The following is a description of a gene set: species: Homo sapiens Human Gene Set: GSE18893_CTRL_VS_TNF_TREATED_TCONV_24H_DN Here we show that tumor necrosis factor (TNF) induced in human T-regulatory cells (Treg), as compared to conventional T cells (Tcon), a transcription program highly enriched for typical NF-κB target genes, such as: the cytokines LTA and TNF; the TNF-receptor super family members FAS, 4-1BB and OX-40; various anti-apoptotic genes; and other important immune-response genes. As an initial approach to examine the cellular program induced by TNF in Tregs versus Tcon cells, we employed microarray gene expression analysis at 2 and 24 hrs following TNF treatment. Genes down-regulated in T conv cells (24h): medium versus TNF. from publication Nagar M, Jacob-Hirsch J, Vernitsky H, Berkun Y, Ben-Horin S, Amariglio N, Bank I, Kloog Y, Rechavi G, Goldstein I (PMID 20181891), and this is the list of marker genes: BCAS3, DDR1, LGALS4, APC, RNF169, GM2A, NRP1, POLD4, CYP4B1, ZFAND5, TBC1D12, RCVRN, RPS6KB2, SLC26A11, HPS3, ESRRB, CENPJ, MOGAT2, RALBP1, FGFBP1, ITGA1, RWDD2A, PRKAR1A, BCORL1, UBXN7 (NCBI Gene Id 26043), PID1, APOLD1, TAF13, POU2AF2, AP3M2, ZDHHC2, ENTREP1, ASPSCR1, PLEKHM3, SCNN1A, TRIM24 (tripartite motif containing 24), TSPO2, PHYHIPL, ZNF454, CFAP119, UBE2B, SPRING1, LIMS4, ABI1, RSRP1, CYTL1, JUNB, TCEANC2, IL21, SP3, MAN2A1, CREB3L4, MXD3, PPP6C (NCBI Gene Id 96749), PRKN, PIWIL2, CWC15 (NCBI Gene Id 51503), BSCL2, RAP2B, TSPAN17, OGFRL1, EMILIN3, LIMK2 (NCBI Gene Id 3985), GRK4, MMP23B, TRAM2, ZBTB2, BCL2A1 (BCL2 related protein A1), ATP11C, PLK3, SLMAP, AJM1, IGSF9, CDC42EP2, LTBR, CSF2, AIP, SLC36A4, RGMB, CDKL4 (NCBI Gene Id 344387), BRD9, CERS5, PPP2CB, BATF2, CCDC62, RP2, EXOC2, EPS15L1, CRTAM, ARL5B, GOLGA2, SLC35B3, GLI3, ATP6V0B, PYCARD, TFF3, DYNC1LI2, KCNS2, CHM, CHIC2, FAH, TMCO3, TGFB1I1, B3GAT1, MPC2, DNMBP, NFKBID, AP3B1, CCDC150, TM4SF20, FUT7, DLX6, AUH, LYSMD3, LNX1, SLC66A1, CEPT1, USP47, FAM171B (NCBI Gene Id 165215), LARP4B, RINL, WDFY4, NXPH3, DGKH, STK36, TF, TAF12, ASH1L, TBX6, MAP7D1, MCTP1, ABHD15, MAF, IPMK, MIR22HG (NCBI Gene Id 84981), CLCN5, BCAR1, ITGB1BP1, CDC14A, DPP7, SYNGR1, SHISAL1, VAV3, MANBAL, CPLANE1, TAF8 (NCBI Gene Id 135763), ATG16L1, LRRC8C, BANK1, FZD5, LEPROTL1, PCDH12, C6orf118, CLASRP, HEXA, GADD45A, CES5A, MROH1, ABCA3 (NCBI Gene Id 21), CLCN4, COL23A1, PPP1R12C, PON2, SNORD89, LRRC52, RAB39B, DRAXIN, ARIH2, TRAPPC2L, PITX3, PLEKHB2, BARHL1, SH3YL1, APOBEC2, FBXO11, PDE4B, NR2F2, YKT6, ATG2A (NCBI Gene Id 23130), CFAP410, SSC5D, PRDM6, SPAG6, C19orf12, PLEKHH1, ATOX1, FAM114A1, APLP1 (NCBI Gene Id 333), TOB1, ADORA3, ACOT8, ERC1, TGM3, ADAMTSL4, CHD5 (NCBI Gene Id 26139), POU6F1, ASAP1, NAA60, EXOC6, PRKCH